Given this list of marker genes ITPR3, COMP, IDUA, BSCL2, SPG11, PLOD3, PDK3, NEB, SLC5A6, PMP22, GBF1, UBAP2L, REEP1, GARS1, SLC39A13, here is a description of the gene set: Human Gene Set: HP_THENAR_MUSCLE_ATROPHY studied in species Homo sapiens Thenar muscle atrophy Wasting of thenar muscles, which are located on palm of the hand at the base of the thumb.